The following is a description of a gene set: studied in species Homo sapiens Catalysis of the reaction: CMP-N-acetylneuraminate + alpha-N-acetylneuraminyl-(2->3)-beta-D-galactosyl-R = CMP + alpha-N-acetylneuraminyl-(2->8)-alpha-N-acetylneuraminyl-(2->3)-beta-D-galactosyl-R. Human Gene Set: GOMF_ALPHA_N_ACETYLNEURAMINATE_ALPHA_2_8_SIALYLTRANSFERASE_ACTIVITY, and this is the list of marker genes: ST8SIA5, ST8SIA4, ST8SIA2, ST8SIA6, ST8SIA3, ST8SIA1